The following is a description of a gene set: Mouse Gene Set: GOBP_RESPONSE_TO_FLUID_SHEAR_STRESS species: Mus musculus Any process that results in a change in state or activity of a cell or an organism (in terms of movement, secretion, enzyme production, gene expression, etc.) as a result of a fluid shear stress stimulus. Fluid shear stress is the force acting on an object in a system where the fluid is moving across a solid surface., and this is the list of marker genes: Pkd1, Pkd2, Spp1, Mef2c, P2rx4, Mmp2, Nos3, Ift88, Akt1 (thymoma viral proto-oncogene 1), Src, Ace, Mapk7, P2rx7, Smad6, Gja1, Abca1, Tfpi2, Klf2, Has2, Ptgs2, Plec, Ptk2b, Hdac3, Cited2 (NCBI Gene Id 17684), Tgfb1, Mtss1, Klf4, Socs5, Nfe2l2, Ass1, Smad7, Xbp1, Hdac5